The following is a description of a gene set: A multisubunit complex that catalyzes the acetylation of histones H4 and H2A. Human Gene Set: GOCC_H4_H2A_HISTONE_ACETYLTRANSFERASE_COMPLEX species: Homo sapiens, and this is the list of marker genes: DMAP1, RUVBL2, ACTB, ACTL6A, MRGBP, MSL3B, RUVBL1 (RuvB like AAA ATPase 1), MORF4L1, ACTL8, MBTD1, POTEE, POTEKP, KAT5, ACTL6B, BRD8 (NCBI Gene Id 10902), VPS72, POTEI, EPC2 (enhancer of polycomb homolog 2), KAT8, ING3, POTEJ, MORF4L2, ACTBL2, YEATS4, TRRAP, MSL3, YEATS2, EP400, ACTG1, EPC1, POTEF, MEAF6